The following is a description of a gene set: A protein ubiquitination process in which a polymer of ubiquitin, formed by linkages between lysine residues at position 29 of the ubiquitin monomers, is added to a protein. K29-linked ubiquitination targets the substrate protein for degradation. species: Homo sapiens Human Gene Set: GOBP_PROTEIN_K29_LINKED_UBIQUITINATION, and this is the list of marker genes: UBE2T, RNF126, PRKN, UBE2D4, UBE3C, TRAF7, UBR5, RNF186, UBE2S, RNF167, ITCH